The following is a description of a gene set: from publication Muranski P, Borman ZA, Kerkar SP, Klebanoff CA, Ji Y, Sanchez-Perez L, Sukumar M, Reger RN, Yu Z, Kern SJ, Roychoudhuri R, Ferreyra GA, Shen W, Durum SK, Feigenbaum L, Palmer DC, Antony PA, Chan CC, Laurence A, Danner RL, Gattinoni L, Restifo NP (PMID 22177921) species: Homo sapiens Serial comparison between Th1 and Th17 tumor-specific cells cultured in vitro and ex vivo after transferred into sublethaly irradiated B6.PL mice. Th17-derived cells acquire Th1-like properties in vivo but maintain a distinct molecular profile. Human Gene Set: GSE26030_UNSTIM_VS_RESTIM_TH17_DAY15_POST_POLARIZATION_UP Genes up-regulated in Th17 cells 15 days post polarization: control versus stimulated with anti-CD3 and anti-CD28., and this is the list of marker genes: VIM, SLC16A1 (solute carrier family 16 member 1), ADAM17, TLR4, LOXL2, BAIAP2, NDUFV1, SCPEP1, MRPL16, PRR5, MPRIP (NCBI Gene Id 23164), PPIP5K1, EBF1, PLAG1, GDE1, LPAR2, EPS8L1, SYTL3, ASRGL1, RCBTB1 (RCC1 and BTB domain containing protein 1), TGFBR1, GOSR2, DUSP3 (dual specificity phosphatase 3), SNAP47, DNAJB5, TRA2B, HEXIM2, NTS, SLC27A6, AMMECR1, DPPA2, INO80C (INO80 complex subunit C), DARS1, GPR141, CHIT1, HMGXB4, EPAS1, BRINP3, LYPLAL1, ANXA8, MAGI3 (membrane associated guanylate kinase, WW and PDZ domain containing 3), KCNJ15, MTREX, SEPTIN11, TAX1BP3, UST, CHCHD7, SLC38A8, RALGPS1, DENND3, BEND6, TMEM109, SLC19A2, HYDIN, GSTK1, NCKAP1, SLC4A8, SEPTIN10, SPG21, SATB2, COMMD10, TPM4, PDGFB, AKAP6, ADD1, NRCAM, ATP11B, WWTR1, NMT2, FLNB, PIK3R6, NRP1, ZMIZ1, HDLBP, LYRM7, PSMC4 (NCBI Gene Id 5704), ASH2L, KCNQ5, PANX1, RETREG3, OSBPL5, SPRY2, IRF8, OXSR1, SGK1, KLF12, CALU (NCBI Gene Id 813), IGF1, CRYZL1, JKAMP (NCBI Gene Id 95097), PTBP3, EVL, KLHL11, GPM6A, CSNK1G1, GFOD1, COMMD3, SLC22A15, TBC1D1, GCA, SPNS3, SF3B5, MAP4K5, PTPRG, CLDND2, KYNU, TLN2, BMPR1B, DTYMK, RELL1 (NCBI Gene Id 768211), MRS2, ENPP2, SAMD3, LASP1, PKP2, STAG1, PASK, NUCKS1, PRF1, DUSP22, CPNE2, SDF2L1, EFCAB2, CNST, VEZF1, JMJD4, SYNE2, ROS1, KDELR3, CPSF3, PPP2CA, STT3B, SPATS2, IMMT, USP37, CUX1, STEAP3, YWHAQ, IDH1, DIO2, TMEM171, ADGRL3, BCAR1, FUCA2, PIPOX, PDK3, PNLIPRP2, TMEM18, DSE, SH2D2A, SLC38A6, VEGFB, ARHGAP10, CSN3, CBX8, STXBP1, FAT1 (NCBI Gene Id 2195), MMD, TAF2, TALDO1, PIK3R3, CNOT9, RNF43, NXPE1, ARHGAP18, PLOD1 (NCBI Gene Id 5351), S100A4, NAGLU, SERTAD2 (NCBI Gene Id 9792), PDCL, NUP50, EXTL3, DYNLL2, CLGN (NCBI Gene Id 1047), TTLL1